Given this list of marker genes NF2 (NF2, moesin-ezrin-radixin like (MERLIN) tumor suppressor), ARVCF, ENSG00000288330, ATP13A2, DDHD2, HMBS, ATXN2, NOTCH3, FRMD5, SCN9A, SMARCE1, TIMM50, SLC9A6, SLC1A4, SLC12A3, CFAP43, ZC4H2, CDKN1A, HTRA1, CHRNB2, JMJD1C, SMARCB1, SPG11, DACT1, IFT57, TRPV4, ATXN10, GABRG2, GBE1, GBA2, APOE, SPAST, CPT1C, MORC2, PIGF, ZEB2, COQ2, PRDM8, FGFR3, NEXMIF, SACS, CDKN1B, IGHMBP2, JRK, RNU4-2, SUFU, RETREG1, CAPN1, POLR3B, SEC24C (SEC24 homolog C, COPII coat complex component), EXT2, COPB1, HS6ST2 (NCBI Gene Id 90161), NOP56, HSPD1, SPTLC2, KIF5A, MEN1, COMT, ADNP, CRH, SPTLC1, PANK2, NOTCH2NLC (notch 2 N-terminal like C), SLC2A1, DNM2, SYNE1, AKT1, DSTYK, NEFL, BIN1, KMT2B, TYROBP, HLA-DQB1, KCNT1, MYO1H, BAP1, SLC44A1, CABP4, WASHC5, GP1BB, GABRA1, FITM2, GJC2, ZMYM2, HIRA, PDGFB, ATXN8OS, GAA, BCR, DEPDC5, SPG7, ALMS1, ISL1, ARX, RSRC1, HPSE2, EIF2AK2, CRKL, MNX1, AP5Z1, HEXB (hexosaminidase subunit beta), AHDC1, SLC20A2, GALNT2, DPYSL5, TBXT, RYR1, COG5, CDKN2C, TERT, DPH5, RREB1, VPS13C, GABBR1, FUZ, ALDH18A1, MAPK8IP3, PLP1 (NCBI Gene Id 5354), VANGL1, FMR1, GALC, ACSF3, CHMP2B, HLA-DRB1, CHRNA4, GABRB3, ZFYVE26, PDGFRB, CYP7B1, SALL1, ALS2, LRIG2, SQSTM1, ATL1, STUB1, SMO, TBCD, TBP, CCL2, RNF170, FARS2, DKK1, TRAF7, AUH, KY, ACBD6, PSAP, VCP, FA2H, NIPA1, UFD1, BNC2, TRIO, KCNC3, CACNA1G, CDKN2B, POT1, GGT1, PIK3CA, COL2A1, RTN2, DMPK, MAPK1, CACNA1H, HACE1 (HECT domain and ankyrin repeat containing E3 ubiquitin protein ligase 1), PSEN2, SIGMAR1 (sigma non-opioid intracellular receptor 1), TTR, PEX11B, NGF, ARSA, ATL3 (NCBI Gene Id 283241), FUS, UBAP1, CHRNA2, MYF6, ABCD1, FLVCR1, VANGL2, TP63, TBX1, SBF1, ERLIN2 (ER lipid raft associated 2), HPS6, CLCNKB, KCND3, SI, SCN4A, MTMR14, DNMT1, here is a description of the gene set: Human Gene Set: HP_IMPAIRMENT_OF_ACTIVITIES_OF_DAILY_LIVING Difficulty in performing one or more activities normally performed every day, such as eating, bathing, dressing, grooming, work, homemaking, and leisure. Impairment of activities of daily living studied in species Homo sapiens